Given this list of marker genes RDH10, DHRS4, ADH4, AKR1B1, DHRS2, AKR1C2, RDH13, DCXR, RDH8, CBR1, KCNAB1, DHRS1, ALDH3A1, AKR1B15, DHRS4L2, DHRS3 (dehydrogenase/reductase 3), AKR1C3, DHRS7, AKR1C4, AKR1E2, CBR3, RDH12, AKR1A1, RDH14, DHRS4L1, AKR1C1, RDH11, AKR1B10, AKR7A2, AKR1D1 (NCBI Gene Id 6718), here is a description of the gene set: Catalysis of the reaction: an alcohol + NADP+ = an aldehyde or ketone + NADPH + H+. studied in species Homo sapiens Human Gene Set: GOMF_ALCOHOL_DEHYDROGENASE_NADPPLUS_ACTIVITY